Given this list of marker genes HLA-DRB1, EXT2, B3GALT6, HFE, PRKG1, ABL1, DZIP1L, BTNL2, PKHD1, EXT1, HMOX1, ATP6V1E1, GCLC, RAI1, SLC26A9, HEY2, TGFB1, CHST14, SLC31A1, SLC34A2, SMAD2, FBN1, TGFBR1, MAT2A, DCTN4, FBXO11, ELN, SLC11A1, TGFBR2, LTBP1, HRAS, CLCA4, CLPB, PRDM10, CEACAM6, TGFB3, WARS2, MYH11, EDNRA, MAP2K1, NRAS, GSTM3, FBLN5, BRAF, SFTPC, LAMB3, ADAMTS2, CAV1, TXNDC15, TSC2, ACTA2, TSC1, COL3A1, SFTPB, SERPINA1, LOX, SMAD3, DSE, LAMC2, DDR2, ABCA3, STX1A, CEACAM3, SLC6A14, FLCN, MIF, KCNN4, TGFB2, CFTR, EFEMP2, MFAP5, IPO8 (importin 8), SMAD4, FOXE3, SLC25A24, LAMA3, ADAMTS3, THSD4, MYLK, SLC9A3, CCR2, here is a description of the gene set: Pneumothorax species: Homo sapiens Accumulation of air in the pleural cavity leading to a partially or completely collapsed lung. Human Gene Set: HP_PNEUMOTHORAX